The following is a description of a gene set: Human Gene Set: GOBP_REGULATION_OF_NEUROTRANSMITTER_TRANSPORT Any process that modulates the frequency, rate or extent of the directed movement of a neurotransmitter into, out of or within a cell, or between cells, by means of some agent such as a transporter or pore. species: Homo sapiens, and this is the list of marker genes: NGF, CASK, BRAF, SLC17A8, SV2B, DRD2, PER2, CPLX4, DRD4 (NCBI Gene Id 1815), GGCX, GPER1, SLC4A8 (NCBI Gene Id 9498), NPY, DVL1, FLOT1, SEPTIN5, CHRNA3, SYT8, MCTP2, GPR151, SLC30A1, OTOF, RIMS1, SYT4, SV2C, RIMS3, SYT11, ITGB1 (integrin subunit beta 1), APP, SYT2, SYT13 (synaptotagmin 13), STX1A, CALM3, SNCA, SYNGR3, FMR1, RAB3B, FBXL20, TOR1A, SYT1, P2RX1, SLC38A2, ADORA2A, TACR2, DYSF, DRD1, CSPG5, SYN1, MICU3, KCNMB4, MEF2C, SNAPIN, DTNBP1, VPS18, PFN2, MCTP1, RAP1A, BGLAP, RAB3A (RAB3A, member RAS oncogene family), PRKN, GIT1, RAB5A, FBXO45, PRKCG, WNT7A, CPLX3, STX1B, PREPL, ITGB3, NOS1, CAMK2A, DRD3, RIMS2, PPFIA2, NLGN1, ATP2A2, FER1L5, LRRK2 (NCBI Gene Id 399472), SYT5, CDK5, PPP3CA, PNKD, RIMS4, P2RY1, RAP1BL, BAIAP3, GFAP, SNCG, GDNF, ASIC1, NF1, KMO, RAP1B, SLC18A3, CACNB4, ATP1A2, GPM6B, PRKCB, TSPOAP1, RAB3GAP1, CACNA1B, HCRT, CHRNB4, GPR158, STXBP1, STXBP5, SNCAIP, MYOF